Given this list of marker genes Pde9a, Mpi, Pde1a, Nudt19, Dpyd, Urah, Galk1, Nt5m, Pde4d, Pde8a, Mtor, Dnph1, Lipa, Pgam1, Eno4, Pfkfb2, Dpys (NCBI Gene Id 76902), Entpd8, Pde4a, Hint1, Prxl2c, Enpp5, Upb1, Upp1, Kat2b, Slc29a1, Uchl1, Entpd4, Nudt5, Hif1a, Galt, Git1, Nudt4, Nt5e, Hdac4, Pfkm, Entpd5, Rptor, Igf1, Gapdhrt2, Ncf1, Pde10a, Adpgk, Gpi1, Pfkl, Xdh, Gck, Nt5c1b, Myog, Prkag1, Jmjd8, Prkag3, Nt5c3, App, Ncf2, Sirt6, Dera, Gpd1, Ucp2, Nudt9, Nt5c, Prkag2, Vnn1, Nudt10, Myc, Zbtb20, Gapdh, Gda, Alpi, Pgam2, Cbfa2t3, Aldoart1, Sik2, Nt5c2, Pde5a, Esrrb, Eno3, Mtch2, Pgk2, Prkaca, Pde7a, Hprt1, Mlst8, Zbtb7a, Ppara, Bcl2l13, Ampd3, Urad, Dctpp1, Gapdhs, Pklr, Hk3, Tigar, Mfsd8, Acot2, Dhtkd1, Pde8b, Hk2, Ada, Ppargc1a, Acat1, Vcp, Aldob, Ogt, Htr2a, Nudt16, Insr, Eno1b, Gale, Pde7b, Pank4, Nudt18, Eno2, Enpp1, Itpa, Pnp, Ogdh, Ifng, Prkaa2, Pde2a, Nnmt, Prkaa1, Tpi1, Fkrp, Khk, Samhd1, Dut, Trim63, Pde4c, Aldoc, Art2b, Actn3 (actinin alpha 3), Nudt17, Fbp1, Ier3, Pkm, Slc4a1, Hkdc1, Pfkp, Nudt8, Mgat1, Ins1, Art2a, Ep300, Entpd1, Pfkfb1, Src, Parp14, Trex1, Cnp, Aox1, Bpgm, Entpd2, Fitm2, Eif6 (NCBI Gene Id 98777), Eno1, Aldoa, Enpp3, Abcd1 (ATP-binding cassette, sub-family D member 1), Uox, Nt5c1a, Foxk2, Ins2, Gapdhrt, Tymp, Foxk1, Cda, Col6a1, Pgk1, Mlycd, Smpdl3a, Il3, Hk1, Slc4a4, Entpd7, Ncor1, Sarm1, Ppp2ca, Nudt11, Mlxipl, Pfkfb3, Ddit4 (NCBI Gene Id 74747), Tkfc, Nudt12, Acot7, P2rx7, Mlx, Nupr1, Nudt15, Cant1, Arl2, Gmpr2, Nudt3, Psen1, Stat3, Aldoart2, Slc2a6, Nudt13, Entpd3, Nudt7, Entpd4b (NCBI Gene Id 100862375), Flcn, Fhit, Arnt, Upp2, here is a description of the gene set: species: Mus musculus Mouse Gene Set: GOBP_NUCLEOSIDE_PHOSPHATE_CATABOLIC_PROCESS The chemical reactions and pathways resulting in the breakdown of a nucleoside phosphate.